Given this list of marker genes SNX4, RGMA, SNX1, NICOL1, IKBKG, CD81, CHUK, HJV, IKBKB, TF, SNX2, HFE, here is a description of the gene set: Human Gene Set: GOMF_TRANSFERRIN_RECEPTOR_BINDING Binding to a transferrin receptor. species: Homo sapiens